Given this list of marker genes CTNNB1, CDH1, CTNNA1, JUP, BRCA1, here is a description of the gene set: Any process that results in a change in state or activity of a cell or an organism (in terms of movement, secretion, enzyme production, gene expression, etc.) as a result of an indole-3-methanol stimulus. Human Gene Set: GOBP_RESPONSE_TO_INDOLE_3_METHANOL species: Homo sapiens